Given this list of marker genes GDF5, PTHLH, SCIN, SIX2 (SIX homeobox 2), PTH, BMPR1B, EFEMP1, RFLNA, NR5A2 (nuclear receptor subfamily 5 group A member 2), SMAD7, ADAMTS7, ZBTB16, RARB, GLI3, CCN4, LOXL2, MBOAT2, GLG1, SHOX2, SOX5, TGFBR1, MAF, SOX9, GDF6, MUSTN1, HOXA11, SMAD3, ACVRL1, PKDCC, TRPS1, PRKG2 (protein kinase cGMP-dependent 2), MDK, PTPN11, AXIN2, RFLNB, NKX3-2, CCN2, SOX6, RUNX2, IHH, ADAMTS12, FGF18, LTBP3, LNPK, ZNF219, RARG, GREM1, CHADL (NCBI Gene Id 150356), BMP4 (bone morphogenetic protein 4), WNT9A, CTNNB1, POR, BMP6, SNAI2, here is a description of the gene set: Human Gene Set: GOBP_REGULATION_OF_CHONDROCYTE_DIFFERENTIATION studied in species Homo sapiens Any process that modulates the frequency, rate or extent of chondrocyte differentiation.